The following is a description of a gene set: Catalysis of the transfer of a methyl group from a donor to a nucleoside residue in a tRNA molecule. Mouse Gene Set: GOMF_TRNA_METHYLTRANSFERASE_ACTIVITY studied in species Mus musculus, and this is the list of marker genes: Tarbp1, Trdmt1, Trmt2a, Trmt10c, Trmt2b, Trmt10b, Trmo, Mettl2, Nsun2 (NCBI Gene Id 28114), Thumpd3, Ftsj1, Trmt11, Trmt13, Mettl6, Nsun4, Tyw3, Trmt5, Thumpd2, Mettl1, Trmt61a, Lcmt2, Bcdin3d, Nsun6, Mettl8, Trmt9b, Nsun3, Trmt10a, Trmt1, Trmt12, Alkbh8, Trmt1l, Trmt44